Given this list of marker genes Dll4, S1pr1, Ptcd2, Pou4f1, Lrp2, Fzd2, Gsc, Bmp2, Fgfr2, Arid5b, Pax7 (paired box 7), Smtnl1, Chd7, Naglu, Rxra, Myl2, Epor, Col11a1, Nkx2-5, Bmp10, Nog, Bmp4, Fzd1, Zfpm2, Ankrd1, Foxh1, Heg1, Dsp, Nrg1, Myf6, Foxc1, Tcf15 (NCBI Gene Id 21407), Myh7, Myl3, Lrp6, Ryr2, Fkbp1a (NCBI Gene Id 14225), Tbx1, Actc1, Angpt1, Mylk2, Egln1, Bmpr1a, Hand1, Cntf (NCBI Gene Id 12803), Mybpc3, Tnni1, Gata4 (NCBI Gene Id 14463, GATA binding protein 4), Myh6, Hey1, Tnnc1, Tnni3, Ednra, Tgfb2, Eng, Lif, Prox1, Smad4, Myf5, Ttn, Notch1, Vangl2, Pitx2, Smad7, Hey2, Xirp2, Tbx20, Mylk, Gmppa, Shox2, Isl1, Rbpj, Pkp2, Tgfbr1, Mir143, Tnnt2, Serp1, Zfpm1, Efemp2, Col3a1, Ube4b, Wnt2, Sirt6 (sirtuin 6), Ccm2l, Foxc2, Med1 (mediator complex subunit 1), Ctnnb1, Mir145a, Tpm1, Tgfbr3, Adarb1, Tcap, Epo, Ly6e, Klk1b1, Tgfb1, here is a description of the gene set: Mouse Gene Set: GOBP_MUSCLE_ORGAN_MORPHOGENESIS The process in which the anatomical structures of muscle are generated and organized. studied in species Mus musculus